Given this list of marker genes Kcnq1, Nup155, Kcna5, Cacna1d, Kcnn2, Scn4b, Kcne5, Cacna1c, Cacna2d1, Gja5, Trpm4, Tbx18, Cxadr, Scn1b, Kcnj5, Scn5a, Hcn4, Rangrf, Scn3b, Ryr2, Scn10a, Ank2, Pkp2, Flna, Cacnb2, here is a description of the gene set: Any process that mediates the transfer of information from one cell to another and contributes to the heart process that regulates cardiac muscle contraction; beginning with the generation of an action potential in the sinoatrial node and ending with regulation of contraction of the myocardium. Mouse Gene Set: GOBP_CELL_CELL_SIGNALING_INVOLVED_IN_CARDIAC_CONDUCTION studied in species Mus musculus